Given this list of marker genes F9, GAS6, PROZ, F7, PROC, F10 (NCBI Gene Id 14058), PROS1, F2, BGLAP, here is a description of the gene set: part of: Gamma-carboxylation, transport, and amino-terminal cleavage of proteins Reactome Pathway: Transport of gamma-carboxylated protein precursors from the endoplasmic reticulum to the Golgi apparatus studied in species Homo sapiens Gamma-carboxylated proteins are moved by anterograde transport from the endoplasmic reticulum to the Golgi apparatus.